The following is a description of a gene set: Marker genes curated from the annotated cluster as represented in the Descartes Human Gene Expression During Development database. studied in species Homo sapiens from publication Cao J, O'Day DR, Pliner HA, Kingsley PD, Deng M, Daza RM, Zager MA, Aldinger KA, Blecher-Gonen R, Zhang F, Spielmann M, Palis J, Doherty D, Steemers FJ, Glass IA, Trapnell C, Shendure J (PMID 33184181) The gene expression program underlying the specification of human cell types is of fundamental interest. The study authors generated human cell atlases of gene expression and chromatin accessibility in fetal tissues. For gene expression, the study authors applied three-level combinatorial indexing to >110 samples representing 15 organs, ultimately profiling ~4 million single cells. The study authors leveraged the literature and other atlases to identify and annotate hundreds of cell types and subtypes, both within and across tissues. Our analyses focused on organ-specific specializations of broadly distributed cell types (such as blood, endothelial, and epithelial), sites of fetal erythropoiesis (which notably included the adrenal gland), and integration with mouse developmental atlases (such as conserved specification of blood cells). These data represent a rich resource for the exploration of in vivo human gene expression in diverse tissues and cell types. Human Gene Set: DESCARTES_MAIN_FETAL_CARDIOMYOCYTES, and this is the list of marker genes: LINC01186, MARCHF11-AS1, FGF12-AS3, MRPL58 (mitochondrial ribosomal protein L58), PRSS42P, ENSG00000238902 (novel transcript), VDAC2P5, FGF12, EIF3KP1, LINC02502, CPT1B, INCA1, ALDOC-AS1, SLC8A1, SORBS2, NAV2-AS2, KBTBD13, TNNI3K, FILIP1, ENSG00000232939 (novel transcript), CTNNA3, NTMT2, JMJD1C-AS1, HCN4, TRIQK, LINC02248, ENSG00000272789, PPP1R12B, RNA5SP327, MIXL1, RBM20, MYBPHL, RYR2, MYBPC3, MYOCD, TRDN-AS1, USP28, SLC27A6, ALPK2, LINC01954, HRAT17, MLIP, FHOD3, KCNJ4